The following is a description of a gene set: Reactome Pathway: N-glycan antennae elongation in the medial/trans-Golgi part of: Transport to the Golgi and subsequent modification In the latter compartments of the distal Golgi the N-Glycan is further modified, leading to the wide range of N-Glycans observed in multicellular organisms. The first step of N-Glycan elongation in the Golgi is the addition of a GlcNAc residue on the alpha 1,3 branch by the enzyme MGAT1 (GlcNAc-TI), which commits the elongation pathway to Complex or Hybrid N-Glycans from Oligomannose N-Glycans. At this point, the pathway bifurcates again to generate Complex or Hybrid N-Glycans. The addition of a GlcNAc in the middle of the two arms of the N-Glycan, catalyzed by MGAT3 (GNT-III), inhibits the removal of the mannoses on the alpha1,3 branches by MAN2 and the addition of a GlcNAc by MGAT2 (GlcNAc-TII), and commits the pathway toward the synthesis of hybrid N-Glycans. Alternatively, the removal of these mannoses and the action of MGAT2 leads to the synthesis of complex N-Glycans.<br>The exact structure of the network of reactions leading to Complex or Hybrid N-Glycans is still not completely described and validated experimentally. Here we will annotate only one generic reaction for each of the enzymes known to participate in this process. For a better annotation on the reactions and genes involved in the synthesis of Complex and Hybrid N-Glycans we recommend the GlycoGene Database (Ito H. et al, 2010) (http://riodb.ibase.aist.go.jp/rcmg/ggdb/textsearch.jsp) for annotations on genes, and the Consortium for Functional Genomics (http://riodb.ibase.aist.go.jp/rcmg/ggdb/textsearch.jsp) for annotation of Glycan structures and reactions. Moreover, a computationally inferred prediction on the structure of this network is available through the software GlycoVis (Hossler P. et. al. 2006). species: Homo sapiens, and this is the list of marker genes: ST3GAL4, B4GALT6, B4GALT3, MGAT2, LHB, MGAT3, ST8SIA2, CHST10, FUCA1, MAN2A1, MGAT4A, ST8SIA6, MGAT4B, ST8SIA3, B4GALT4 (NCBI Gene Id 8702), CGA, B4GALT5, MGAT5, MAN2A2, B4GALT1, CHST8, ST6GAL1, FUT8, B4GALT2, FUT3, MGAT4C